The following is a description of a gene set: In this study, an extensive analysis was conducted to define meta-programs (MPs) capturing intra-tumor heterogeneity across a spectrum of tumor types. The approach utilized non-negative matrix factorization (NMF) to analyze each cell type separately within individual tumor samples. This involved the analysis of malignant cells, macrophages, fibroblasts, endothelial cells, epithelial cells, T-cells, and B-cells. NMF was executed with varying parameter values (K=4, 5, 6, 7, 8, 9), thereby generating 39 programs for each cell type per sample. Each NMF program was summarized by the top genes based on NMF coefficients.\nRobust MPs were then delineated for each cell type using a set of stringent criteria, including recurrence within the same tumor, similarity to programs in other tumors, and non-redundancy within a tumor. Subsequently, these robust NMF programs were clustered (per cell type) based on Jaccard similarity, leading to the identification of MPs associated with each cell type.\nTo enhance the quality of the MPs, a refinement steps were undertaken, involving the removal of MPs suspected of reflecting low-quality data (with an overrepresentation of ribosomal proteins or mitochondrial-encoded genes), single-study inclusion, or similarity to miss-annotated cell types. species: Homo sapiens Genes upregulated in subsets of cells of a given type within various tumors Human Gene Set: GAVISH_3CA_METAPROGRAM_EPITHELIAL_EMT_LIKE_2 from publication Gavish A, Tyler M, Greenwald AC, Hoefflin R, Simkin D, Tschernichovsky R, Galili Darnell N, Somech E, Barbolin C, Antman T, Kovarsky D, Barrett T, Gonzalez Castro LN, Halder D, Chanoch-Myers R, Laffy J, Mints M, Wider A, Tal R, Spitzer A, Hara T, Raitses-Gurevich M, Stossel C, Golan T, Tirosh A, Suvà ML, Puram SV, Tirosh I (PMID 37258682), and this is the list of marker genes: CCL2, ANXA1, MMP7, KRT7, MALL, IL32, CST6, EMP3, LAMB3, TUBA1A, DEFB1, TYMP, TM4SF1, TPM1, CCND1, RARRES1, GBP1, SPTSSB, HLA-DQA1, CDC42EP1, KRT17, RND3, TMSB4X, SAA1, NFKBIA, BIRC3, ANXA2, ANXA3, CLDN3, CLDN1, LTF, CALD1, TNFRSF12A, CD24, ANKRD36C (ankyrin repeat domain 36C), CCL28, TNFAIP2, VIM, IFI27, C15orf48, PLAUR, KRT23, SOD2, TACSTD2, LGALS1, TGFB2, TIMP1, RBP1, THBS1, SFN